The following is a description of a gene set: studied in species Homo sapiens Human Gene Set: GOBP_DERMATAN_SULFATE_PROTEOGLYCAN_BIOSYNTHETIC_PROCESS The chemical reactions and pathways resulting in the formation of dermatan sulfate proteoglycans, which consist of a core protein linked to a dermatan sulfate glycosaminoglycan. The dermatan sulfate chain is composed of the repeating disaccharide unit beta-(1,4)-D-hexuronic acid-beta-(1,3)-N-acetyl-D-galactosamine. Tthe former can be a mixture of sulfated and nonsulfated D-glucuronic and L-iduronic acids, and the latter can be O-sulfated. Dermatan sulfate chains are covalently linked to serine/threonine residues (O-linked) of the core protein via a tetrasaccharide linker sequence (xylose-galactose-galactose-glucuronate)., and this is the list of marker genes: CHST12, DSE, UST, CSGALNACT2, CSGALNACT1, B3GALT6, B3GAT3, CHST14